The following is a description of a gene set: Reactome Pathway: Regulation of gene expression in beta cells part of: Regulation of beta-cell development Two transcription factors, PDX1 and HNF1A, play key roles in maintaining the gene expression pattern characteristic of mature beta cells in the endocrine pancreas. Targets of these regulatory molecules include genes encoding insulin, the GLUT2 glucose transporter, the liver- (and pancreas) specific form of pyruvate kinase and other transcription factors including HNF4A, HNF4G, and FOXA3. PDX1 expression in turn is controlled by the activities of MAFA, FOXA2, and PAX6, and negatively regulated via AKT. studied in species Homo sapiens, and this is the list of marker genes: INS, NEUROD1, HNF1A, RFX6, HNF4G, AKT3, FOXA2, AKT2, MAFA, FOXA3, HNF4A, AKT1, FOXO1, NKX6-1, PAX6, SLC2A2, IAPP, GCK, PDX1, PKLR, NKX2-2